Given this list of marker genes Gmpr (guanosine monophosphate reductase), Ampd1, Ampd3, Ampd2, Hprt1, Pnp, Gmpr2, Aprt, Ada, here is a description of the gene set: Any process which produces inosine monophosphate from derivatives of it, without de novo synthesis. Mouse Gene Set: GOBP_IMP_SALVAGE studied in species Mus musculus